The following is a description of a gene set: Human Gene Set: GSE13493_DP_VS_CD8POS_THYMOCYTE_UP T cell development relies on the precise developmental control of various cellular functions for appropriate positive and negative selection. Previously, gene expression profiling of peptide-driven negative selection events in the N15 TCR class I MHC-restricted mouse and D011.10 TCR class II MHC-restricted mouse has offered insights into the coordinate engagement of biological processes affecting thymocyte development. However, there has been little comparable detailed in vivo global genome expression analysis reported for positive selection. We used microarrays to identify the genes differentially expressed during CD8 single positive T cell development in N15 TCR transgenic Rag2 deficient mice. Genes up-regulated in comparison of CD4 CD8 thymocytes versus CD8 thymocytes. from publication Choi YI, Duke-Cohan JS, Ahmed WB, Handley MA, Mann F, Epstein JA, Clayton LK, Reinherz EL (PMID 19027330) studied in species Homo sapiens, and this is the list of marker genes: MAST3, NCK2, P3H4, MRGPRE, NT5C3B, TIAM1, INO80C, CD99L2, FAM193B, COL9A3, L3MBTL3, MAGEF1, CHL1, PEX5, HSPA4L, MED13, CD8A, R3HDM2, USP3, RIPOR1, MPP1, KCNN4, CRAMP1, HIGD1C, STX6, ARID1A, FBXW7, RBAK, LPAR6, DENND4C, ENTREP1, CASK, ZDHHC17, FCER2, ATP6V1G1, MUS81, CSRNP1, NMNAT1, ABCC8, MIER1, MEX3B, VPS13D, DIP2A, RNF166, CASQ1, AP3M2, JUP, B3GALNT1, PRKCB, BTK, PTBP2, ATP6V1D, CDK5R2, LYST, CASP6, MRAP2, GRIK2, SYPL2, CNOT1, ZNF646, ARMCX1, UBTD1, ZNF653, KIF13B, PLGRKT, BEND5, PLEKHG2, ARAP2, A4GALT, H3-5, PLXDC2, PIP5K1B, ITGAL, RHOH, TTLL1, FYB1, SLC9A9, CSNK1E, FMNL2, CORO2B, PIK3CA, MR1, LIX1L, MT1E (NCBI Gene Id 4493), AGAP1, MANBAL, RP2, OGA, FTL, WSB2, GADD45A, MIR22HG, GNAI3, CEND1, PTK7, TDRD5, FHIP2A, UBE4B, PTCH1, IL4R, PRKRA, CNPPD1, CLPTM1, RPS6KB2, MRTFB, UBE2S, SLC12A4, AHSG (NCBI Gene Id 780898), RABGAP1L, CERK (ceramide kinase), MEX3A, ACTR5, MARCKSL1, CTNNBIP1, ERO1A, RFX5, KIDINS220, FBXO41, RAB22A, FBXW11, TRPV2, TSR3, GTF2H4, GABARAPL2, YPEL2, SLCO3A1, WWP2, SLC2A13, TMEM35A, CNOT6, SERINC5, PPIL2, TP53BP2, PKD2, CPPED1, PRAMEF8, LDB1, SENP7, RBPJ, MARCHF6, PLA2G5, BAP1, SH3BP2, SEC14L1, IFIT2, PABPN1, TMCC3, TPRA1, INSL5, ABI3, DBNDD1, RSRP1, COL27A1, JTB, SHF, FIRRE, CD8B, PRPF38B, NPC1L1, RAB33B, CD81, ZNF667, LCORL, ZCCHC9, DGAT1, TTC9C, CHMP1B, ALG11, ZBTB34, SETD7, CACNB1, CYBRD1, ETFRF1, GMEB2, C19orf33, H1-0, TCF12 (NCBI Gene Id 6938), SH3RF3, SLC22A5, SNN, NKIRAS1, RDH11, MYL3, MORC2, TSPYL4, CDC42SE2, NAA35, ARHGEF10, TRIM56, NATD1, TRIM24, HAUS2, PDE5A, DUSP11, C21orf91, HCLS1, TP73, P2RY10, BBOF1